Given this list of marker genes CKB, ADAM12 (NCBI Gene Id 8038), SAMSN1, MEF2C, DUSP6, FOSL2, SLC2A3, MTSS1, RUNX1T1, DEPTOR, ELK3, EDIL3, ECM1, RANBP2, CD34 (NCBI Gene Id 947), IFI16, TSPAN7, ID1, BAALC, here is a description of the gene set: species: Homo sapiens Human Gene Set: DUNNE_TARGETS_OF_AML1_MTG8_FUSION_DN Genes down-regulated in Kasumi-1 cells (acute myeloid leukaemia (AML) with the t(8;21) translocation) after knockdown of the AML1 MTG8 fusion by RNAi. from publication Dunne J, Cullmann C, Ritter M, Soria NM, Drescher B, Debernardi S, Skoulakis S, Hartmann O, Krause M, Krauter J, Neubauer A, Young BD, Heidenreich O (PMID 16652140) The chromosomal translocation t(8;21) is associated with 10-15% of all cases of acute myeloid leukaemia (AML). The resultant fusion protein AML1/MTG8 interferes with haematopoietic gene expression and is an important regulator of leukaemogenesis. We studied the effects of small interfering RNA (siRNA)-mediated AML1/MTG8 depletion on global gene expression in t(8;21)-positive leukaemic cell lines and in primary AML blasts using cDNA arrays, oligonucleotide arrays and real-time reverse transcription-polymerase chain reaction (RT-PCR). Suppression of AML1/MTG8 results in the increased expression of genes associated with myeloid differentiation, such as AZU1, BPI, CTSG, LYZ and RNASE2 as well as of antiproliferative genes such as IGFBP7, MS4A3 and SLA both in blasts and in cell lines. Furthermore, expression levels of several genes affiliated with drug resistance or indicative of poor prognosis AML (BAALC, CD34, PRG2, TSPAN7) are affected by AML1/MTG8 depletion. In conclusion, siRNA-mediated suppression of AML1/MTG8 cause very similar changes in gene expression pattern in t(8;21)-positive cell lines and in primary AML blasts. Furthermore, the results suggest that the specific targeting of AML1/MTG8 function may be a promising approach for complementing existing treatment strategies.